The following is a description of a gene set: Neighborhood of SMC1L1 NULL in the GNF2 expression compendium Neighborhood of SMC1L1 Human Gene Set: GNF2_SMC1L1 studied in species Homo sapiens, and this is the list of marker genes: LMNB1, SMC1A, ELAC2, LAS1L, HNRNPF, DHX15, NUP153, UQCRC2, CENPM, BANF1, U2SURP, PTBP1, DLD, TCP1, PSME2, RRM2, RBMX, POLA2, PSIP1, HNRNPA3P1 (NCBI Gene Id 10151), HNRNPK, SFPQ, MCM5, SNRPG, PSMA3, EED (embryonic ectoderm development), MCM3